The following is a description of a gene set: Human Gene Set: GOBP_MITOCHONDRIAL_TRANSLATION The chemical reactions and pathways resulting in the formation of a protein in a mitochondrion. This is a ribosome-mediated process in which the information in messenger RNA (mRNA) is used to specify the sequence of amino acids in the protein; the mitochondrion has its own ribosomes and transfer RNAs, and uses a genetic code that differs from the nuclear code. studied in species Homo sapiens, and this is the list of marker genes: MRPL19, DAP3, MRPL34, LARS2, MRPL24, C1QBP, MRPS12, RCC1L, WARS2, MRPS2, TARS2, MRPL23, GADD45GIP1, MIURF, MRPL21, MRPS30, MRPL3, UQCC2, DDX3X, MRPS14, MRPL39, MRPL9, MRPS24, MRPL36, TACO1, MRPL17, MRPS11, MRPS15 (NCBI Gene Id 64960), MRPL33, PTCD1, MRPL32, MRPL42, GFM2, MRPL13, MRPS25, RPUSD4, MRPL47, MRPL1, MRPS26, MRPL38, GFM1, AARS2, MRPL51, SARS2, CHCHD1, MRPS28, QRSL1, MRPS21, HARS1, MRPS35, NGRN, EARS2, TSFM, RPUSD3, METTL8, MRPS31, MRPL43, MRPS9, IARS2, MTRF1L, NSUN3, DARS2, GATC, PTCD3, MRPL37, MPV17L2, MALSU1, MRPL10, MTRF1, MRPL44, MRPL12, MRPL18, MRPL49, MRPL52, MRPL40, MRPL15, MRPL45, SHMT2 (NCBI Gene Id 6472), MRPL4, MRPL35, MRPS34, MRPL22, MRPL16, MTG1, ALKBH1, MRPS18C, MRPS7, GATB, MRPL54, MRPL20, MRPL53, YARS2, COA3, MTIF2, FASTKD2, MRPL41, MRPS23 (mitochondrial ribosomal protein S23), MRPS6, RARS2, RMND1 (NCBI Gene Id 55005), MRPL11, MRPS33, MRPL48, MRPS10, TUFM (Tu translation elongation factor, mitochondrial), MRPS27 (mitochondrial ribosomal protein S27), MTIF3, MRPS18B, OXA1L, MRPS16, FASTKD3, TRMT10C, MRPL46, AURKAIP1, MTG2, MRPS22, MRPL27, TRUB2, GARS1, MRPL14, CDK5RAP1, MRPL50, MRPS17, MRPS18A, MRPL58 (NCBI Gene Id 3396), MRPL30, MRPL28, MRPS5, MRPL2, MRPL55, MRPL57, LRPPRC